The following is a description of a gene set: part of: Response of endothelial cells to shear stress This event has been computationally inferred from an event that has been demonstrated in another species.<p>The inference is based on the homology mapping from PANTHER. Briefly, reactions for which all involved PhysicalEntities (in input, output and catalyst) have a mapped orthologue/paralogue (for complexes at least 75% of components must have a mapping) are inferred to the other species. studied in species Mus musculus electronically inferred by orthology from the curated human pathway Reactome Pathway: Turbulent (oscillatory, disturbed) flow shear stress activates signaling by PIEZO1 and integrins in endothelial cells, and this is the list of marker genes: Nfkb1, Ptpn1, Ikbkb, Rela, Itga5, Anxa2 (annexin A2), Ppp2r2a, Ppp2r1b (NCBI Gene Id 73699), Nfkbia, Capns2, Yap1, Ptk2